Given this list of marker genes EXOC7, MAP9, NUP62, RAB11A, RAB11FIP3 (NCBI Gene Id 9727), ARF6, DCDC1, ANKRD53, KIF20B, CDCA8, POLDIP2, AURKB, INCENP, WNK1, BIRC5, ECT2, here is a description of the gene set: studied in species Homo sapiens Any process that modulates the frequency, rate or extent of mitotic cytokinesis. Human Gene Set: GOBP_REGULATION_OF_MITOTIC_CYTOKINESIS